The following is a description of a gene set: EP/NE-ADRB-cAMP signaling pathway. Pathway ID: N01345. Pathway type: Reference. Pathway class: nt06234 cAMP signaling. Human Gene Set: KEGG_MEDICUS_REFERENCE_EP_NE_ADRB_CAMP_SIGNALING_PATHWAY studied in species Homo sapiens Pathway Definition from KEGG: (EP,NE) -> ADRB2 -> GNAS -> ADCY -> cAMP -> PKA -> PLN, and this is the list of marker genes: ADCY3, PRKACB, GNAS, ADCY4, ADCY5 (adenylate cyclase 5), ADCY7 (NCBI Gene Id 113), ADCY6, ADRB2, ADCY8, ADCY1, ADCY9, PLN, ADCY2, PRKACG, PRKACA